The following is a description of a gene set: part of: Signal Transduction studied in species Homo sapiens Hedgehog (Hh) is a secreted morphogen that regulates developmental processes in vertebrates including limb bud formation, neural tube patterning, cell growth and differentiation. Hh signaling also contributes to stem cell homeostasis in adult tissues. Downregulation of Hh signaling can lead to neonatal abnormalities, while upregulation of signaling is associated with the development of various cancers.<br><br>Hh signaling is switched between 'off' and an 'on' states to differentially regulate an intracellular signaling cascade that targets the Gli transcription factors. In the absence of Hh ligand, cytosolic Gli proteins are cleaved to yield a truncated form that translocates into the nucleus and represses target gene transcription. Binding of Hh to the Patched (PTC) receptor on the cell surface stabilizes the Gli proteins in their full-length transcriptional activator form, stimulating Hh-dependent gene expression.<br><br> Reactome Pathway: Signaling by Hedgehog, and this is the list of marker genes: TUBB2B, PRKACG, DYNC2H1, ITCH, SCUBE2, GAS1, IQCE, TUBB3, PTCH2, SHH, FUZ, PSMA4, RPGRIP1L, NUMB, TUBB2A, GRK2, PSMA1, CUL3, PSMD1, TUBB4B, PSMA6, RPS27A, PSMB3, IFT88, CSNK1A1, ADCY6, DISP2, TUBA3C, DZIP1, PRKACA, SMO, PSMD12, SUFU, SEM1, EFCAB7, PSMC5 (NCBI Gene Id 5705), SPOPL, GLI2, SMURF2, TULP3, KIF7, PSMD3, TTC21B, ERLEC1, SMURF1 (SMAD specific E3 ubiquitin protein ligase 1), IFT122, PSMB5, ADRM1, EVC2, PSMB6, PTCH1, PRKAR1A, KIF3A, ARRB2 (NCBI Gene Id 409), ADAM17, ADCY2, PSMA3, PSMB2, EVC, IFT57, PRKACB, TUBB1, DERL2, ADCY3, PSMD11, PRKAR1B, TUBB4A, HHIP, ADCY9, PRKAR2B, UBB, IFT52, CUL1, GPR161, ADCY8, OS9, ULK3, GLI1, SPOP, PSMD7, ADCY7, TUBB6, TUBA1C, TUBA3D, WDR35, PSMC1, HHAT, NOTUM, TUBA1B, IFT140, TUBA4A, PSMD6, PSMD13, GSK3B, IHH, PSMC2, PSMC3, DRC4, ADCY1 (NCBI Gene Id 449484), GNAS, PSMA5, UBC, UBA52, IFT172, WDR19, PSMD8, ADCY10, DHH, PSMD2 (NCBI Gene Id 5708), PSMA2, INTU, ADCY4, OFD1, SKP1, BTRC, ARRB1, PSMD14, CDC73, PSMB4, CDON, SEL1L, MKS1, PSMC4, PSMB1, GPC5, TUBA1A, PRKAR2A, PSMC6, P4HB, PSMB7, PSMA7, SYVN1 (NCBI Gene Id 84447), RBX1, VCP, BOC, GLI3, ADCY5